The following is a description of a gene set: Human Gene Set: GOCC_SARCOPLASMIC_RETICULUM_MEMBRANE The lipid bilayer surrounding the sarcoplasmic reticulum. species: Homo sapiens, and this is the list of marker genes: SRI, REEP5 (NCBI Gene Id 94845), AKAP6 (NCBI Gene Id 9472), DMPK, JPH1, RYR1, FKBP1B, ART1, CAMK2D, TMEM38A, PLN, ATP2A3, CASQ1, CAMK2B, FKBP1C, MRLN, CHERP, CAMK2G, SLN, SYNE2, NOS1, RTN2, ASPH, ATP2A2, JPH3, DHRS7C, CASQ2, TMEM38B, NOS1AP, ITPR2, RYR3, KLHL41, ATP2A1, SRL, STRIT1, STIM1, JPH2, RYR2, JSRP1, FKBP1A, TRDN, SLC30A7, TMEM109, JPH4